The following is a description of a gene set: Type A brachydactyly species: Homo sapiens Human Gene Set: HP_TYPE_A_BRACHYDACTYLY, and this is the list of marker genes: SRCAP, WNT5A, GJA1, GDF5, DVL1, RAI1, ROR2, PUM1, PUF60, IGF2, MYCN, RBBP8, BMP2, SCNM1, ERF, NOG, TFAP2B, TBX5, BMPR1B, NIN, HOXD13, PTH1R, RUNX2, GNB2